The following is a description of a gene set: Human Gene Set: GOBP_PHOTORECEPTOR_CELL_OUTER_SEGMENT_ORGANIZATION A process that is carried out at the cellular level and results in the assembly, arrangement of constituent parts, or disassembly of the outer segment of a photoreceptor cell, a sensory cell that reacts to the presence of light. The outer segment of the photoreceptor cell contains the light-absorbing materials. species: Homo sapiens, and this is the list of marker genes: CRB1, PCARE, MFSD2A, RP1, AHI1, CDHR1, PRPH2, NPHP4, IFT20, ROM1, IFT140, CNGB1, BBS4